Given this list of marker genes HLA-DMB, HMOX1, HLA-A, TNFSF13B, CD1B, SAMSN1, PLXDC2, HS3ST3B1, HLA-G, TBXAS1, IFNG, ASGR1, CD1C, CD1A, TMT1A, RIN2, HLA-C, NFKBID, HLA-DRA, AGPAT1, HLA-DPB1, CSF1R, TLR8, PRKCD, TLR7, RTN1, CD74 (CD74 molecule), CSF2RA, CD1D, HLA-DRB4, HLA-DQB1, GCH1, ASPH, IL1R2, SLAMF8, CD86, FUT7, HLA-DRB1, HLA-DPA1 (major histocompatibility complex, class II, DP alpha 1), FAR2, here is a description of the gene set: Many vaccines induce protective immunity via antibodies. Systems biology approaches have been used to determine signatures that can be used to predict vaccine-induced immunity in humans, but whether there is a 'universal signature' that can be used to predict antibody responses to any vaccine is unknown. Here we did systems analyses of immune responses to the polysaccharide and conjugate vaccines against meningococcus in healthy adults, in the broader context of published studies of vaccines against yellow fever virus and influenza virus. To achieve this, we did a large-scale network integration of publicly available human blood transcriptomes and systems-scale databases in specific biological contexts and deduced a set of transcription modules in blood. Those modules revealed distinct transcriptional signatures of antibody responses to different classes of vaccines, which provided key insights into primary viral, protein recall and anti-polysaccharide responses. Our results elucidate the early transcriptional programs that orchestrate vaccine immunity in humans and demonstrate the power of integrative network modeling. species: Homo sapiens from publication Li S, Rouphael N, Duraisingham S, Romero-Steiner S, Presnell S, Davis C, Schmidt DS, Johnson SE, Milton A, Rajam G, Kasturi S, Carlone GM, Quinn C, Chaussabel D, Palucka AK, Mulligan MJ, Ahmed R, Stephens DS, Nakaya HI, Pulendran B (PMID 24336226) Human Gene Set: LI_PBMC_MENACTRA_AGE_18_45YO_CORRELATED_WITH_ANTI_DT_ANTIBODY_3DY_POSITIVE Genes positively correlated with antibody response in peripheral blood mononuclear cell in adults (18-45) (anti-DT antibody-correlation profile) after exposure to Menactra, time point 3D